The following is a description of a gene set: studied in species Mus musculus Mouse Gene Set: REACTOME_GLUCAGON_TYPE_LIGAND_RECEPTORS Glucagon-type ligand receptors, and this is the list of marker genes: Sctr, Glp1r, Ghrhr, Vip, Gnb1, Gnb4, Adcyap1r1, Vipr1, Sct, Gnb5, Gnb2, Gng3, Gng11, Gcg, Gipr, Gng8, Gnb3, Gng10, Glp2r (NCBI Gene Id 93896), Gngt2, Gng2, Gcgr, Gng13, Gip (NCBI Gene Id 14607), Gng4, Vipr2, Ghrh, Gnas, Gng5, Gng12, Gng7, Gngt1, Adcyap1